The following is a description of a gene set: studied in species Homo sapiens Hyperpigmentation of the skin Human Gene Set: HP_HYPERPIGMENTATION_OF_THE_SKIN A darkening of the skin related to an increase in melanin production and deposition., and this is the list of marker genes: NOD2, NBN (nibrin), MSH2, TP53RK, C1R, GNB2, FANCC, NOP10, NPM1, SLX4, TWIST2, CD28, PALB2, UBR1, XRCC2, SVBP (small vasohibin binding protein), SLC29A3, POLA1, ARL6IP6, FERMT1, SKIC3, AAAS (NCBI Gene Id 8086), RFX7, C1S, MAPK1, MAN1B1, SMARCAL1, USP8, TFR2, ALAS2, IL12A, BRCA2, CDH23, HLA-DRB1, GPNMB, USB1, CYBA, CSTA, UBE2T, RET, NF1, DKC1, IL12RB1 (NCBI Gene Id 3594), PTEN, CLCN7, ABCD1, KDSR, RERE, MAP2K2, MRAP, LZTR1, ERCC8, MMP2, TP63, BUB1B, PTPN11, HPS1, USP48, ESCO2, BTNL2, PDE11A, LEMD3, ERCC2, TP53, PHIP, GJB3, SDHC, FANCI, BPTF, NRAS, XPA, ALDH3A2, AIP, CDKN2C, CDKN1C, MAP2K1, TRIP13, ATP2A2, SDHB, SMARCA2, BRCA1, HCCS, FANCA, IL6, SPRED1, PLAG1, SH3PXD2B, CDKN1B, CYBB, POLH, GPR101, KRAS, IGF2, RBBP8, GNAQ, H4C5, FANCF, POLE, POGLUT1, SASH1, TMC6, CYBC1, CRIPT, UROS, COX7B, ST3GAL5, HAMP, BUB1, UBAP2L, POU2AF1, KNSTRN, HMGA2, ATM, SDHD, NSD1, FGFR1, COL7A1, MC2R, KITLG, MLH1, COPB1, GNAS, IFNG, MEN1, BLM, LBR (NCBI Gene Id 653311), TMEM127, TAF4, PANK2, HFE, CPOX, PPOX, SLC40A1, DDB2, STEAP3, PIK3CD, SKIC2, AEBP1, SOX10, HRAS, NHP2, KMT2D, SMARCAD1, CARD14 (caspase recruitment domain family member 14), IKBKG, KLLN, SLC6A19, USF3, MPV17, CWC27, CLTRN, CYP11A1, NDUFB11 (NADH:ubiquinone oxidoreductase subunit B11), RPA1, SRD5A3, ERCC1, IRF5, SMG8, WRAP53, STAR, TNPO3, SLC27A4, PSENEN, CHN1, KRT14, CIB1, RECQL4, PDGFRA, FANCG, XPC (XPC complex subunit, DNA damage recognition and repair factor), GJB6, GJB4, RTEL1, KCNH1, POFUT1, TGM5, GBA1, REV3L, KCNN3, DNASE1L3 (deoxyribonuclease 1L3), NR3C1, ANKLE2, MED12 (NCBI Gene Id 9968), NNT, NOTCH3, MAFB (NCBI Gene Id 9935), MAX, TYMS, TOMM7, TINF2, SEC23A, HGD (homogentisate 1,2-dioxygenase), MC1R, SMS, PAX6, TOP3A, BMP2, KANSL1, SEC23B, NR0B1, MYO5A, CHD8, FANCD2, SET, SDHA, ABCB6, LYST, CTLA4, RAD51C, AKT1, SPIB, GMPPA, APC, TERT, BRIP1, KRT5, FANCL, MAPRE2, TUBB, ACD, TNFRSF1A, WBP11 (WW domain binding protein 11), DSTYK, ACP5, CBL, FGFR3, KIT, STK11, NCF4, ATP6V1B2, CDKN1A, IGF1, OCA2, RIT1, IRF1, PARN, KDM6B, BUB3, SGPL1, COL3A1, EP300, TSC1, TNFSF15, ERCC6, PLXND1, ERCC5, UROD, FANCB, MTOR, ANAPC1, SLC9A1, SHOC2, TXNRD2, UBE2A, PPP1CB, DPP9, RAF1, ERCC4, TMC8, NCF2, SALL4 (spalt like transcription factor 4), SNRPN, GNA11, COL17A1, PDGFRB, CAPRIN1, HEPACAM, CYP11B1, FANCM, RPS27, HJV, RFWD3, ADAR, TNFRSF1B, KDM6A, MMEL1, BMP6, PIGN, FANCE, ANTXR2, CREBBP, APOE, GATA1, TSC2, WASF1, NCF1, CASR, PIK3CA, ABCC9, LMNA, ZMPSTE24, CDKN2B, RAD51, PRKAR1A, BRAF, JAK3, DDX11, PSMB8, ADH5, TERC, PLEC, PORCN, ATRX, KDM5C, ERCC3, DHX30, GJA1, HSD3B2, VHL, CEP57, MCM4, ACTB, HBB, PIDD1, NF2, RBM28, MAD2L2, CTC1, BANF1, INSR, MSH6, SLF2, SPINK5, IRF4, PMS2, PCNT, IL7, APC2 (NCBI Gene Id 10297, APC regulator of WNT signaling pathway 2), TRAPPC11